The following is a description of a gene set: studied in species Homo sapiens Human Gene Set: GOBP_NEGATIVE_REGULATION_OF_AMYLOID_BETA_CLEARANCE Any process that stops, prevents or reduces the frequency, rate or extent of amyloid-beta clearance., and this is the list of marker genes: MYOCD, CYP51A1, MIR1908, TNF, MIR34A, IFNGR1, SRF, PLA2G3, HMGCR, IFNG, SREBF2, LRPAP1